Given this list of marker genes CORO1A, TRAC, CARD9, AP3B1, AIRE (autoimmune regulator), KNSTRN, CD3E, TLR8, STAT1, ZNF341, ZAP70, PSMB10, DCLRE1C, RORC, CD40LG (CD40 ligand), TFRC, IL2RA, JAK3, IKBKB, MVK, WDR1, IL17RA, STAT3, LCK, CD3D, CD3G, IL2RG, NCF2, RFX5, CD247, TRAF3IP2, PIK3CD, DOCK2, FOXN1, here is a description of the gene set: studied in species Homo sapiens Human Gene Set: HP_CHRONIC_ORAL_CANDIDIASIS Chronic oral candidiasis Chronic accumulation and overgrowth of the fungus Candida albicans on the mucous membranes of the mouth, generally manifested as associated with creamy white lesions on the tongue or inner cheeks, occasionally spreading to the gums, tonsils, palate or oropharynx.